The following is a description of a gene set: The directed movement of snRNA, small nuclear ribonucleic acid, into, out of or within a cell, or between cells, by means of some agent such as a transporter or pore. studied in species Homo sapiens Human Gene Set: GOBP_SNRNA_TRANSPORT, and this is the list of marker genes: RAN (NCBI Gene Id 87046), SNUPN, NCBP2, PHAX, NCBP3, NCBP1